The following is a description of a gene set: from publication Usher MG, Duan SZ, Ivaschenko CY, Frieler RA, Berger S, Schütz G, Lumeng CN, Mortensen RM (PMID 20697155) Human Gene Set: GSE23308_CTRL_VS_CORTICOSTERONE_TREATED_MACROPHAGE_DN Genes down-regulated in macrophages: untreated versus corticosterone. Inappropriate excess of the steroid hormone aldosterone, which is a mineralocorticoid receptor (MR) agonist, is associated with increased inflammation and risk of cardiovascular disease. MR antagonists are cardioprotective and antiinflammatory in vivo, and evidence suggests that they mediate these effects in part by aldosterone- independent mechanisms. We used affymetrix to characterize the effect of Mineralocorticoid Receptor deletion on macrophage transcriptional profile, and identify its requirement in normal glucocorticoid signalling. species: Homo sapiens, and this is the list of marker genes: CLDND1 (NCBI Gene Id 56650), DUSP11, PHLDA1, PARP8, MMP14, RBM12, SLC30A6, MRPS2, FAM32A, PTGER4 (NCBI Gene Id 5734), RAP2C, NFE2L2, WDR77, PRLR, TSR1, AP2S1, GPA33, CAMKK1, PSPC1, NMU, TAB2, VASP, BRPF1, STX12, CYRIB, RRP8, SF1, CDC42EP4, TRAPPC13, SLC3A1, RBM5, CCRL2, NCK1, OAF, MVP, LCN2, TMEM183A, FOXC2, STK17B, PAFAH1B2, HEXIM1, PTGS1, KPNB1, FAM227B, PCDHA12, AEN, SLAMF6, TNFRSF9, MARK3 (NCBI Gene Id 4140), PTGES, STXBP3, EIPR1, CALCRL, NOP2, KIF2C (kinesin family member 2C), NLRP3, CYP4A22, CXCL2, LOXL3, ESYT3 (NCBI Gene Id 83850), CPZ, NCF4, HGD, PTGDR2, DGKA, COMMD7, PDPK1, CCR7, RAD51AP1, YARS1, SSBP4, PHLDB1, RAVER1, IARS1, ABRACL, KHDC4, TRMT1L (tRNA methyltransferase 1 like), CH25H, SYT7, ZC3H15, IL1B, ABT1, FGFR1OP2, NXF1 (NCBI Gene Id 10482), ERO1A, IGSF6, LSG1, PGP, ACTB, SIGLEC7, POLR2D, KLHL25, GORASP2 (NCBI Gene Id 26003), LRG1, CNTFR, VASN, NINJ1, LGALS4, TNFAIP8L1, TRIP13, ZCCHC3, PLAUR, RAB10, SAV1, GPM6B, TRIP10, DNAJA1, CDV3, ARPC5, INHBA, CER1, CYTH3, SPTLC2, GTF2F1, ELMO3, SERPINE2, SYPL2, REXO4, TBC1D13, SLC35A5, LPAR1, MED29, CDKN2B, HTT, CASP4, TYMS, MRPL3, IKBKE, PTPN6, LYVE1, TNFAIP8, GDA, ETV4, GTF2H3, NUBP2, PCYT2, SIM1, CCN1, GSPT1, RPS6KB1, PPP1R11, GDF15, SAC3D1, DKK3, IRX3, FBN1, YIPF4, RALB, WNT9A, HES1, TMEM63B, PIM3, CD200, TGFB1I1, GRB10, FDFT1, RAP1A, PSMD7, ZNRF1, CARM1, ATXN2, MPP2, SLC44A1, MBD1, LDLR, RND3, GLIPR2, CCN4, IL4I1, KIF1A, CASP1, SLC26A7, CREB3, ATXN7L1, MYO1B, PLEKHG6, TNIP2, LTBR, TMED5, HERPUD1, LYN, GPR88, MT2A (NCBI Gene Id 4502), GAS7, GSAP, EGLN3, ID1, SURF4, TAGLN, EIF4EBP1, SAA1, SECISBP2L, VAPA, DNAH5, TANK, SPARC, PPP2CA, PDE4B, MINDY3, CCN2